The following is a description of a gene set: from publication Chen Y, Wang X (PMID 31504780) studied in species Homo sapiens Human Gene Set: MIR454_5P Genes predicted to be targets of miRBase v22 microRNA hsa-miR-454-5p in miRDB v6.0 with MirTarget v4 prediction scores > 80 (high confidence targets)., and this is the list of marker genes: ATXN7L3B, MYCL, GIGYF2, TRIM50, GPR176, COP1, SERPINH1, PCID2 (PCI domain containing 2), GID8, NIPA1, TMEM47, ZNF860, MAPK1, PUM2, TLN2, ADGRF4, FGFBP2, SP4, ZBED4, TDG, RAP1B, STARD8, GDF9, SYNE2, CACHD1